Given this list of marker genes Lypla2, Hpgd, Cyp4f15, Cyp4f18, Cyp4f14, Dpep2, Cyp4f40, Abhd16a, Cyp4f13, Dpep1, here is a description of the gene set: The chemical reactions and pathways resulting in the breakdown of icosanoid. Mouse Gene Set: GOBP_ICOSANOID_CATABOLIC_PROCESS species: Mus musculus